Given this list of marker genes Cacnb2, Cacng8, Cacna1c, Cacng4, Cacng6, Cacng7, Cacna2d2, Cacnb1 (NCBI Gene Id 12295), here is a description of the gene set: Mouse Gene Set: REACTOME_PHASE_0_RAPID_DEPOLARISATION studied in species Mus musculus Phase 0 - rapid depolarisation